The following is a description of a gene set: electronically inferred by orthology from the curated human pathway species: Mus musculus part of: Cytochrome P450 - arranged by substrate type Reactome Pathway: Fatty acids This event has been computationally inferred from an event that has been demonstrated in another species.<p>The inference is based on the homology mapping from PANTHER. Briefly, reactions for which all involved PhysicalEntities (in input, output and catalyst) have a mapped orthologue/paralogue (for complexes at least 75% of components must have a mapping) are inferred to the other species., and this is the list of marker genes: Cyp4a30b, Cyp4f39, Cyp4a10, Cyp4a31 (NCBI Gene Id 666168), Cyp2f2, Cyp4f18 (cytochrome P450, family 4, subfamily f, polypeptide 18), Cyp4a12a, Cyp2a12, Cyp4f15, Cyp4a29, Cyp2d22, Cyp4f40, Cyp2a4, Cyp4b1, Cyp2j6